The following is a description of a gene set: Human Gene Set: PEDRIOLI_MIR31_TARGETS_DN from publication Pedrioli DM, Karpanen T, Dabouras V, Jurisic G, van de Hoek G, Shin JW, Marino D, Kälin RE, Leidel S, Cinelli P, Schulte-Merker S, Brändli AW, Detmar M (PMID 20479124) studied in species Homo sapiens Genes down-regulated in primary LEC cells (lymphatic endothelum) upon overexpression of MIR31. The lymphatic vascular system maintains tissue fluid homeostasis, helps mediate afferent immune responses, and promotes cancer metastasis. To address the role microRNAs (miRNAs) play in the development and function of the lymphatic vascular system, we defined the in vitro miRNA expression profiles of primary human lymphatic endothelial cells (LECs) and blood vascular endothelial cells (BVECs) and identified four BVEC signature and two LEC signature miRNAs. Their vascular lineage-specific expression patterns were confirmed in vivo by quantitative real-time PCR and in situ hybridization. Functional characterization of the BVEC signature miRNA miR-31 identified a novel BVEC-specific posttranscriptional regulatory mechanism that inhibits the expression of lymphatic lineage-specific transcripts in vitro. We demonstrate that suppression of lymphatic differentiation is partially mediated via direct repression of PROX1, a transcription factor that functions as a master regulator of lymphatic lineage-specific differentiation. Finally, in vivo studies of Xenopus and zebrafish demonstrated that gain of miR-31 function impaired venous sprouting and lymphatic vascular development, thus highlighting the importance of miR-31 as a negative regulator of lymphatic development. Collectively, our findings identify miR-31 is a potent regulator of vascular lineage-specific differentiation and development in vertebrates., and this is the list of marker genes: PLVAP, KANK1, PKHD1L1, PSORS1C1, SOCS6 (NCBI Gene Id 9306), SBDS, GVINP1, ANXA3, PTGDS, SLC4A3, TNFSF14, MYOM3, PLCB1, ZNF233, TSLP, ZNF396, UBD, ARSD, GGTLC2, SLC5A2, MTMR12, PLAC8, GLRX, PSG3, CFAP70, ACOT4, RHOU (NCBI Gene Id 58480), SLC6A4 (NCBI Gene Id 6532), ZNF343, BHLHE41, SIAE, MYOM1, TFPI2, IFIT2, ENO3, OTULINL, GSAP, STC1, AADAC, IDNK, BCLAF3, MOSPD3, CMTM3, VPS13B, CX3CL1, REXO1, CCL20, CD55, PLA2G4C, ANKRD35, AKR1C1, SPIN3, RBPJ, NID1, H1-4, RPA4, GTF2IRD2 (GTF2I repeat domain containing 2), CD93, AVIL, ZNF333, SMIM19, IL34, TMSB4X, CEP135, CEL, LAMA2, ARHGEF12, P4HB, MAN2C1, GSKIP, AKAP12, SNAP29, PCLO, MED26, MMP11, DSC2, HEY1, NOS1AP, TMEM171, TACC1, VWF, IL3RA, ZNF532, CWF19L2, TMEM140, MAP3K7CL, NR4A3, CACNB2, GPR157, DCLK3, ALMS1P1, IFIT3, PCDHGC5 (NCBI Gene Id 56097), TRIM14, PPARA, CNST, LDB2, DNAJC5G, ITGB7, AKR1C2, DCTN4, ZMAT1, CLU, TSPAN7, TAS2R45, FGF7P6, FERMT3, TMOD1, PNPLA7, OR1L1, XKR6, NFKB2, P2RX7, SECISBP2L, UGCG, C22orf46P, CSAD, PLPP1, RAB38, KCNIP1, KIAA0040, SVIL, RAET1E, ZNF667, LINC00242, NEO1, RCSD1, PPL, MMP16, GSTCD, CHRNE (cholinergic receptor nicotinic epsilon subunit), YPEL1, NQO1, CD276, AIF1L, RUFY3, COL17A1, MLIP, KLF6, GUSBP11, NACAD, SUPT3H (SPT3 homolog, SAGA and STAGA complex component), SLC44A5, DOCK1, AFAP1L1, ZMYM6, ROBO1, IFITM10, LINC02981, PEG10, ZFAND3, TNFRSF6B, SPP1, CREM, SLC22A17, EDNRB, SV2B, PIWIL4, GLRB, OR51V1, DOK2, HOXD10, SOD2, CDKN1C, CHD9, DISC1 (NCBI Gene Id 80138, DISC1 scaffold protein), ODAD2, MFRP, MDN1, PLXNB3, TLR2, BIRC3, ATXN1L, CAP1, SNX5, CORO7, STK36, CLGN, KLHL18, SCARF2, UHMK1, KIF21A, ABCA7, MYCBP2, SAMD9, PRKAA2, P2RX4, ANGPT4, ENDOD1, VEGFD (vascular endothelial growth factor D), CAND2, MMRN1, DHRS7, IRAK2, HSPA12B, LYVE1, PPP1R9A, SLC16A3, OR6A2, VCPIP1, TNFAIP3 (TNF alpha induced protein 3), RGS20, TRIM54, CXCL8, ERV3-1, TMEM177, EMILIN2, OR5E1P, DIP2C, GAD2, EVA1C, ANP32CP, ABCA4, PROX1, SBF2, NCF2, VPS4B, TIMP3, TNFRSF4 (TNF receptor superfamily member 4), LAMTOR3, PDZD2, CSF3R, IL23A, TRMT9B, MIB2, INHBC, TSPOAP1, SLIT3, LATS2, PLEKHB1, TRIM66, NUP188, SMAD1, SPOCK2, NOD2, WWC3, FLRT2 (NCBI Gene Id 9822), HLTF, SLC31A1, PCDHA13 (NCBI Gene Id 56136), NR4A2, PPM1K, SENP7, FBXL4, FEM1C, BHMT2, BMP8A (NCBI Gene Id 79787), MYO1D, CXCL12, PCDHB14, SETBP1, DEFA5, ZDHHC20, ZNF846, CEP120, CACNA1H, NFKBIZ, GBP2, KCNMB4, TXNRD1, AK9, ENKUR, RD3, CPNE7, ZNF568, NAV2, BACE1, PNOC, ADAMTS9, PDGFD, IFIT1, SAMD9L, VCAM1, OPN3 (opsin 3), NDFIP1, ITGB4, ARSH, EPHB6, CHMP3, VAT1, IL32, NOTCH2NLA, PROKR1, N4BP2L1, PRCP, GLB1L, LRG1, MAT1A, ZFAND6, SMPDL3B, ANO6, LINC01949, BVES, MYBPHL, USP12, CARD11, PMCH, NRP1, PPP1R14A, MMP10, PCBD1, DAPK2, DNAJC14, SELE (NCBI Gene Id 6401), LKAAEAR1, NUDT6 (NCBI Gene Id 11162), SLC46A3, RRAD, SETD2, DCAF12L2, HRH2, CA4 (carbonic anhydrase 4), TGFBR2, SERPINE2, RASD1, EMP1, FLOT1, SNAI3-AS1, AFDN, GUCY1A1 (guanylate cyclase 1 soluble subunit alpha 1), SUGT1P3, RASGRF2, PDK4, SMG9, PDZD7, PLA1A, ACE, FGL2, SLC26A4, ADAT2 (NCBI Gene Id 134637), RELB, HHAT, RASSF2, MX1, RINL, RAMP2, SPRY4, GCH1, CTSO, CDC26, EBF1, CPM, CXCL2, ADGRL3, ARHGAP29, ATP8B5P, PLA2G4A, HLA-DOA, HTRA3, CLDN5, WFDC3, EXD3, VIP, FGF12, TMEM243, DDX6 (NCBI Gene Id 1656), ABCG2, FAIM2, MYD88, NPAS2, CACTIN, ETV2, OSBPL6, ZNF177, HLX, DEF6, CLN8, FOXC2, ANGPT2, CCIN, LDLRAD4, SLC7A11, MBLAC2, CAMK2N1, PLXND1, LTB, CDH13, LITAF, ICAM1, PNMT, ZNF574, NOXA1, ZC3H6, ARL6IP5, FMNL1, KLF5, CYP46A1, ACKR3, SGCD (sarcoglycan delta), MAFK, NRL (NCBI Gene Id 4901), RNASE1, WNT10B, ZNF415, DESI2, DSG2, IL37, ADAM32, FAT2, NEAT1, CDC14A, NPHP3, ZNF304, NRCAM, STUM (NCBI Gene Id 91267), IFIH1, CD164, ANKRD20A11P, SH3TC2, PADI4, STMN2, PCDHB16, MMP7 (matrix metallopeptidase 7)